Given this list of marker genes Cacng4, Cacng7, Cacnb1, Cacna2d2, here is a description of the gene set: electronically inferred by orthology from the curated human pathway studied in species Mus musculus part of: Cardiac conduction This event has been computationally inferred from an event that has been demonstrated in another species.<p>The inference is based on the homology mapping from PANTHER. Briefly, reactions for which all involved PhysicalEntities (in input, output and catalyst) have a mapped orthologue/paralogue (for complexes at least 75% of components must have a mapping) are inferred to the other species. Reactome Pathway: Phase 0 - rapid depolarisation